The following is a description of a gene set: from publication Cui A, Huang T, Li S, Ma A, Pérez JL, Sander C, Keskin DB, Wu CJ, Fraenkel E, Hacohen N (PMID 38057668) Genes negatively differentially expressed in cell type: CD4+ T cell upon treatment with cytokine: TNF-α in mouse lymph nodes in vivo. studied in species Mus musculus Cytokines mediate cell-cell communication in the immune system and represent important therapeutic targets. A myriad of studies have highlighted their central role in immune function, yet we lack a global view of the cellular responses of each immune cell type to each cytokine. To address this gap, the authors created the Immune Dictionary, a compendium of single-cell transcriptomic profiles of more than 17 immune cell types in response to each of 86 cytokines (>1,400 cytokine-cell type combinations) in mouse lymph nodes in vivo. A cytokine-centric view of the dictionary revealed that most cytokines induce highly cell-type-specific responses. For example, the inflammatory cytokine interleukin-1β induces distinct gene programmes in almost every cell type. A cell-type-centric view of the dictionary identified more than 66 cytokine-driven cellular polarization states across immune cell types, including previously uncharacterized states such as an interleukin-18-induced polyfunctional natural killer cell state. Mouse Gene Set: CUI_T_CELL_CD4_TNFA_RESPONSE_DN, and this is the list of marker genes: Tagln2, Klf2, Klf6, Hspa1b, Hspa1a, Uba52, Rasgrp2, Adgre5, Lcp1, Macf1, Smpdl3a, Myl6, Mxd4, Selenop, H1f4, Cd9, Lsp1, Fxyd5, Trbc2, S100a13, Saraf, Thy1, Fos, Crip1, Rgs10, Septin1, Id3, Gimap3, Atp11b, Emp3, Tecpr1, Timp2, Btg2, Jun, Cd3g, Capg, Flna, H1f2, S100a10, Tdrp, Cotl1